Given this list of marker genes PRDM2, SUV39H1 (NCBI Gene Id 6839), SUV39H2, PRDM9, SETDB1, here is a description of the gene set: species: Homo sapiens Human Gene Set: GOMF_HISTONE_H3K9_TRIMETHYLTRANSFERASE_ACTIVITY Catalysis of the reaction: L-lysyl9- + 3 S-adenosyl-L-methionine = 3 H+ + N6,N6,N6-trimethyl-L-lysyl9- + 3 S-adenosyl-L-homocysteine. This reaction is the successive addition of three methyl groups to the unmethylated lysine residue at position 9 of histone H3, producing histone H3K9me3.